Given this list of marker genes Rbm39, Epha2, Ptpn13, Tnfaip1, Nisch, Muc13, Pik3r1, Pkp4, Frs3, Rnd2, Ubxn11, Vangl1, Ktn1, Lrrc1, Depdc1b, Wdr6, Arhgap35, Dlg5, Nudc, Plxnd1, Vangl2, Tfrc, Scrib, Golga3, Rbmx, Frs2, Fam83b, Prag1, Arhgap1, Pik3r2, Dsg1a, Ankrd26, Kctd13, Txnl1, Aldh3a2 (aldehyde dehydrogenase family 3, subfamily A2), Kidins220, Cav1, Ckap4, Arhgap5, Dst, Kif14, Fnbp1, Bltp3b, here is a description of the gene set: Mouse Gene Set: REACTOME_RND2_GTPASE_CYCLE RND2 GTPase cycle species: Mus musculus